Given this list of marker genes Lipa, Mef2c, Setd4, Hmga2, Shc1, Ace, Fgfr3, Lef1, Il6, Flt3l, Mir223, Map3k3, Lgals3, Pth, Fgfr2, here is a description of the gene set: Mouse Gene Set: GOBP_CELL_PROLIFERATION_IN_BONE_MARROW The multiplication or reproduction of cells, resulting in the expansion of a cell population in the bone marrow. studied in species Mus musculus